The following is a description of a gene set: species: Homo sapiens Genes down-regulated in basal mammary epithelial cells compared to the luminal ones. Epithelial cells within the normal breast duct seem to be the primary target for neoplastic transformation events that eventually produce breast cancer. Normal epithelial cells are easily isolated and propagated using standard techniques. However, these techniques almost invariably result in populations of cells that are largely basal in character. Because only approximately 20% of human breast cancers exhibit a basal phenotype, our understanding of the disease may be skewed by using these cells as the primary comparator to cancer. Further, because germ line mutations in BRCA1 yield breast cancers that are most often of the basal type, a comparison of normal basal and luminal cells could yield insight into the tissue and cell type specificity of this hereditary cancer susceptibility gene. In this report, we describe a simplified and efficient method for isolating basal and luminal cells from normal human breast tissue. These isogenic cells can be independently propagated and maintain phenotypic markers consistent with their respective lineages. Using these cultured cells, we show that basal and luminal cells exhibit distinct responses to ionizing radiation. Basal cells undergo a rapid but labile cell cycle arrest, whereas luminal cells show a much more durable arrest, primarily at the G(2)-M boundary. Molecular markers, including p53 protein accumulation, p53-activated genes, and BRCA1 nuclear focus formation all correlate with the respective cell cycle responses. Further, we show that short-term cultures of human breast tissue fragments treated with ionizing radiation show a similar phenomenon as indicated by the biphasic accumulation of p53 protein in the basal versus luminal layer. Together, these results indicate that normal basal cells have a transitory cell cycle arrest after DNA damage that may underlie their increased susceptibility to transformation after the loss of functional BRCA1. Human Gene Set: HUPER_BREAST_BASAL_VS_LUMINAL_DN from publication Huper G, Marks JR (PMID 17409405), and this is the list of marker genes: BACE2, GAD1, IDH2, KRT18, FUT3, IL32, ALCAM (NCBI Gene Id 214), CST6, CLDN4, SCCPDH (saccharopine dehydrogenase (putative)), ANPEP, LOXL1, EFEMP1, MYO5C, GABRP, TM4SF1, MLPH, PROM1, HLA-F, WFDC2, KRT81, KRT8, IGFBP4, NR2F2, FUCA1, SEMA3B, CNN3, CCN1, METRN, KRT86, DDAH1, PSMB8, UGCG, MIA, KRT19, HLA-B, ADAMTS5, ENO2, IGFBP3, DKK1, LCN2, HMGA1, ANXA11, MYO6, GPRC5A, TPM4, PSMB9 (proteasome 20S subunit beta 9), VWA1, INHBB, KLK6, MALL, TBL1X, BIK, KRT15, PLAAT3, CLDN7, TNFAIP2, HLA-G